Given this list of marker genes COX5B, MT-CO2, COX7A2L, MT-CO1, COX8A, COX6A2, COX6B2, COX7C, COX4I2, COX6A1, COX6C, COX7B, COX4I1, COX5A, COX7A2, COX8C, COX7A1, MT-CO3, COX6B1, here is a description of the gene set: Pathway Definition from KEGG: CytC -- CxIV -> H2O Electron transfer in Complex IV. Pathway ID: N00998. Pathway type: Reference. Pathway class: nt06252 Mitochondrial ROS formation. species: Homo sapiens Human Gene Set: KEGG_MEDICUS_REFERENCE_ELECTRON_TRANSFER_IN_COMPLEX_IV